The following is a description of a gene set: from publication Chen Y, Wang X (PMID 31504780) species: Mus musculus Genes predicted to be targets of miRBase v22 microRNA mmu_miR_3057_3p in miRDB v6.0 with MirTarget v4 prediction scores > 80 (high confidence targets). Mouse Gene Set: MIR_3057_3P, and this is the list of marker genes: Shank3, Ino80d, Klrk1, Sft2d2, Tbc1d13, Ptpn3, Gfpt1, Lyz3, Zfp950, Ube2d3, Tshz3, Mfap1b, Snx11, Vangl2, Igsf9b, Homer2, Atmin, Zmym4, Stra6l, Cacna2d1, Zfp811, Nufip1, Zfp592, Dag1, Dnajc13, Sbno1, Niban2, Raph1, Sesn1, Sf3a3, Tusc2, Cdyl, Nop9, Ccdc97, Exog, Mtmr11, Cd164, Dennd4c, Ptprk, Trim35, Chrd, Celf4, Acaa1b, Fut10, Dusp22, Cbl, Yars1, Zfp607b, Ggt5, Ttc9, Klhdc8b, Elovl4, Pkd1, Smcr8, Slc26a11, Aak1, Msrb3, Apc2, Gnpnat1, Dip2b, Aar2, Arid2, Slc31a1, Lao1, Tnk2, Strbp, Jam2, Tmed9, Lmo1, Abi1, Cyth3, Mroh1, Kctd7, Mc3r, Fam131b, Mnt, Sh3bgrl, Arhgef3, Yap1, Ncs1, Psd3, Fbxo31, Asap1, Ssbp2, Tent4b, Kcnf1, Prdm9, Rab1a, Aplf, Foxo4, Als2cl, Ptprt, Bbox1, Usb1, Susd6, Mprip, Zfp616, Tnrc6a, Lmo3, Trpv1, Nat2, Neurog2, Galnt1, N4bp1, Tbx4, Cltc, Zfp764, Ampd2, Tspyl5, Gcat, Nr6a1, Pcdh10, Acvr2b, Dcaf11, Itpr2 (NCBI Gene Id 545892), Psme3, Denr, Adgrl2, Tbc1d14, Slc17a3, Gabpb2, Prrg3, Col1a2, Gpld1, Cul2, Flt4, Ppp1r11, Plppr4, Ilkap, Bcl9 (NCBI Gene Id 77578), Adcy7, Uqcrb, Il17ra, Nfatc3, Heyl, Bbs4, Slamf6, Srf, Nemp1, Gabrd, Psma5 (proteasome subunit alpha 5), Otop3 (NCBI Gene Id 69602), Rnf6, Thsd1, Zfp704